The following is a description of a gene set: studied in species Homo sapiens Human Gene Set: HP_SPONDYLOEPIPHYSEAL_DYSPLASIA Spondyloepiphyseal dysplasia A disorder of bone growth affecting the vertebrae and the ends of the long bones (epiphyses)., and this is the list of marker genes: CCN6, ACAN, COL2A1, IARS2, COL11A1, RPL10, RNU4ATAC, CHST3, TRPV4, NMNAT1, MBTPS1, TRAPPC2, SMARCAL1